Given this list of marker genes TPCN1, TRPM6 (transient receptor potential cation channel subfamily M member 6), KCNAB2, NALF2, SLC5A12, SLC30A5, PKD2L1, ORAI2, KCNJ14, SLC20A1, KCNV1, SLC12A9, SLC23A2, ATP1A4, SLC39A8, CATSPER4 (NCBI Gene Id 378807), KCNAB3, ANO9, KCNB1, SCN8A, TRPC4AP, KCNH8, KCNG4, P2RX7, CABP1, SLC17A2, KCNE3, KCNIP1, ABCC9, SGK2, MAGT1, SLC4A8, KCNK1, ADRB2, TRPM2, OPRM1, GRIN2B, SLC17A3 (NCBI Gene Id 10786), CAV3, SLC6A13, SLC34A1, KCNA5, MICU2, KCNH4, REM1, FHL1, GRIA1, SLC12A8 (solute carrier family 12 member 8), ATP2B4, TMBIM4, SLC34A2, TMEM37, AMBP, SHROOM2, FXYD6, FXYD7, PHPT1, TMC1, ITPR1, PKD1L1, SLC4A7, CACNA1F, ATP2C1, KCNJ2, DPP6, SLC30A7, ASIC2, SLC6A3, SLC13A4, MCOLN1, SLC9C1, SLC39A4, SLC10A2, PSEN1, SLC30A3, MCUB, SLC6A8, SLC17A6, SCN5A, SLC10A1, SLC5A1, SLC39A10, GRIK2, SCN11A, KCNQ4, SLC6A2, TRPV2, SLC5A6, SLC9A3, REM2, SLC5A10, SLC38A4, ATP2A2, KCNJ5, SLC9A1, SLC8A1 (solute carrier family 8 member A1), TRPC1, TRPM4, SLC5A11, SLC29A1, FXYD6P3, NIPAL2, FAIM2, SNTA1, KCNC2, YWHAE, CACNB1, AKAP9, GHITM, GRINA, KCND3, FXYD4, SLC9B2 (NCBI Gene Id 133308), TMEM94, SLC4A11, CACNG7, SCN9A, KCNJ15, KCNK16, NIPAL1, CHRNA9, RASA1, KCNA6, RYR3, KCNN4, KCNJ16, CHRNA7, SLC24A1, SLC39A1 (NCBI Gene Id 96436), SLC1A2, SLC6A7, KCNK6, RRAD, CACNA1H, GRIK5, TRPA1, SLC39A13, NRXN1, CACNA1I, DRD2, SLC12A1, TMBIM6, TMBIM1, SLC6A9 (solute carrier family 6 member 9), KCNE2, SGK1, KCNV2, SLC18A1, CLDN16, SLC5A3, TMEM175 (NCBI Gene Id 84286), SUMO1, GRIK3, PKD1L3, STIMATE, SLC1A7, KCNG1, FGF13, SLC6A6, SCN7A, TMCO1, SLC46A3, SLC5A4, SLC20A2, SCNN1D, CABP5, TMEM168, ASIC3, NOS1, KCNIP4, NIPAL3, KCNS1, TMCO3, CATSPER2, SLC40A1, SCN2B, FKBP1B, BNIP1, NCS1, CACNG5, TMEM38A, SLC17A1, CACNA1E, KCNE4, KCNC3, GRIK4, HCN3, ZDHHC13, AKT1, KCNC4, SCNN1G, CACNA1B, KCNH7, CNGA4, GRIN2D, AGT, CACNA2D1, SLC8A3, SLC12A7, NIPA1 (NCBI Gene Id 6686), SLC31A2, KCNK12, KCNT2, SLC1A3, AMIGO1, SLC41A3, CABP2, KCNJ18, PRKG1, KCNH5, CACNA2D2, TTYH1, SCN3A, NALF1, CACNG6, ATP4A, SCN10A, YWHAH, NRXN2, ORAI3, PTPN3, KCNS2, SLC10A3, SLC39A9, OXSR1, KCNA10, RANGRF, TRPM7, KCNK2, P2RX4, TMPRSS3, TMC2, SLC24A2, TRPM3, ABCC8, CALHM1, KCNA2, HPCAL4, CABP4, STIM1, SLC6A18, KCNQ1, SCNN1A, SLC12A2, KCNJ1, ATP2B2, SCN2A, ANK2, PKD2, KCNJ8, MICU1, TUSC3, TNNI3, CNNM2, CALM3, FXYD2, SCLT1, KCNIP2, CACNA2D4, SCN4B, CATSPER1, HCN1, SLC5A7, CACNB2, SLC5A9, SLC4A9, SCNN1B, STIM2, FGF11, KCNH3, ATP2B1, SLC1A6, NIPAL4, KCNA3, KCNU1, SLC17A8, GRIN3A, SLC17A7, KCNJ12 (NCBI Gene Id 92081), KCNAB1, KCNN2, GPM6A, KCNK4, SLC39A5, SLC39A2, SLC6A14, CACNG8, KCNQ3, SNAP25, DRD4, CALM1, MRS2, KCNE5, ATP2B3, KCNJ9 (NCBI Gene Id 7820), GRM3, KCNH1, SLC4A10, CACNG4, TRPV6, GRM2, SLC12A6, KCNK3, SLC30A4, SLC18A2, SLC39A7, NPY2R, PKD1, SLC6A20, LRRC38, ATP13A1, CAV1, CACNG1, SLC9A4, PANX3, TRPV1, KCNK5, SLC39A11, PANX1, HAMP, P2RX1, KCNA7, KCNK17, MCU, CACNA1D, CHRNA10, SLC24A4 (solute carrier family 24 member 4), SLC9A2, KCNJ3, CACNA2D3, CNGB1, PDE4B, ATP12A, TRPM5, ASIC1, KCNK7, WWP2, SLC9B1, SLC38A2, FXYD1, SLC31A1, SLC17A4, SLC41A2, SRI, SLC39A6, SEC61A1, SLC9A6, NEDD4L, CNGA3, SLC25A37, KCNK9, TPCN2, SCN1B, ASIC4, SLC11A2, SLC9A8, SLC6A1, SLC4A4, SLC6A12, AQP1, PDE4D (phosphodiesterase 4D), SLC28A1, CALHM3, TRPM8, TRPV4, FXYD5, KCNA4, KCNJ10, FKBP1A, SLC9A5, KCNMB3, SLC30A9, CNNM4, NEDD4, MMGT1, DPP10, KCND2, SCN4A, UCP3, RASA3, SLC38A1, SLC9A9, GRIN1, CAMK2D (calcium/calmodulin dependent protein kinase II delta), CACNA1S, SLC6A4 (NCBI Gene Id 6532), TRPM1, CACNG3, SLC13A1, ATP7B, MICU3, RYR2, ANK3, KCNK15, KCNS3, ARPP19, KCNG2, ATP7A, SLC5A5, RYR1, ENSA, SLC30A8, KCNJ13, GPLD1, CNGA1, CACNA1A, LRRC52, KCNQ2, TRPV3, SLC23A1, KCNJ11, SLC9A7, SLC22A1, ATP1A1, KCNT1, C8orf44-SGK3, NALCN, STX1A (syntaxin 1A), GRIA3, ATP2A1, ATP1B1, NPY, PCSK9, KCNB2, SLC24A5, SLC30A1, KCNN3, LRRC55, STK39, SLC1A1, MCOLN3, CCDC51, SLC24A3, TMEM38B, PKP2, KCNJ4, KCNH6, TSPOAP1, CRISP1, KCNMB2, SLC9C2, KCNIP3, TMEM87A, SLC12A3, CACNA1G, PKD1L2, HCN4, MFSD2A, SLC39A3, TSPAN13, TRPC3, SLC5A8, FGF12, GPD1L, TRPC6, SLC39A14, CACNG2, LETM1, KCNF1, CACHD1, SLC5A2, ATP4B, SLC38A5, HCN2, KCNC1, SLC38A3, SLC10A4, KCNMB4, PKDREJ, KCNA1, PRKCB, ITGAV, FGF14, COMMD1, GSTM2, MCOLN2, SLC6A5, SLC10A5, TRPC7, SLC28A3, SLC12A4, ATP1A2, ATP1A3, CATSPER3, KCNMB1, KCNQ5, KCNK18, GLRX, LRRC26, ATP2C2, SLC30A10, ITPR3, SLC30A6, SLC11A1, SLC38A7, SGK3, RSC1A1, TRPC4, FXYD3, PACSIN3, GEM, SLC28A2, KCNH2, TRPV5, SLC8B1, GRIN3B, KCNMA1, SLC10A6, CACNB3, GRIN2A, SCN1A, SCN3B, DLG1, CCT8L2, GRIK1, KCNK10, CACNB4, KCNN1, KCNJ6, SLC6A11, CACNA1C, CHP1, SLC25A28, ITPR2, SLC12A5, ATP2A3, SLC8A2, TMEM165, SLC13A5, TRPC5, KCNK13, CNGA2, SLC13A2 (solute carrier family 13 member 2), SLC4A5, FLNA, ORAI1, NIPA2, PKD2L2, KCNE1, CALM2, KCND1 (potassium voltage-gated channel subfamily D member 1), KCNG3, ASIC5 (acid sensing ion channel subunit family member 5), SLC41A1, CUL5, SLC13A3, SLC6A15, SLC39A12, SLC34A3, SLC30A2, here is a description of the gene set: Enables the transfer of metal ions from one side of a membrane to the other. species: Homo sapiens Human Gene Set: GOMF_METAL_ION_TRANSMEMBRANE_TRANSPORTER_ACTIVITY